Given this list of marker genes NELFB, BAX, NTRK3 (NCBI Gene Id 4916), here is a description of the gene set: When neuronal cells are deprived of the NTRK3 (TRKC) ligand NTF3 (NT-3), NTRK3 functions as a dependence receptor, promoting apoptosis. The pro-apoptotic activity of NTRK3 is implicated in proper nervous system development, by dictating the number of surviving sensory neurons. In the absence of its ligand, NTRK3 undergoes caspase-dependent cleavage, resulting in release of the NTRK3 killer fragment (KF). The NTRK3 KF, in complex with NELFB (COBRA1), inserts into the mitochondrial membrane, promoting cytochrome c release and apoptosome-mediated apoptosis. part of: Signaling by NTRK3 (TRKC) species: Homo sapiens Reactome Pathway: NTRK3 as a dependence receptor